The following is a description of a gene set: species: Mus musculus Binds to and modulates the activity of adenylate cyclase. Mouse Gene Set: GOMF_ADENYLATE_CYCLASE_REGULATOR_ACTIVITY, and this is the list of marker genes: Raf1, Rgs2, Gnas, Calm1, Gnaz, Gnai1, Grm7, Adgrv1, Calm2, Calm3